Given this list of marker genes TMEM176A, IFI27, INPP5B, INMT, VNN1, CPT2, REEP6, XIST, FMO1, C11orf54, CYP2B6, G0S2, LASP1, EHHADH, ALDOB (aldolase, fructose-bisphosphate B), CAT, ALDH1A1, SLC31A1, RGN, IDI1, CD1D, PDZK1, LYZ, HSD17B10 (NCBI Gene Id 50828), SULT1B1, PHLDA1, SERPINA12, AKR1C4, FABP1, OSTC, KLKB1, NOCT, S100A10, IGFALS, MIX23, OTC, TP53INP2, BPHL, ALDH3A2, ZAP70, RDH16, CA3, here is a description of the gene set: Human Gene Set: VARELA_ZMPSTE24_TARGETS_DN species: Mus musculus Top genes down-regulated in liver tissue from mice with knockout of ZMPSTE24. from publication Varela I, Cadiñanos J, Pendás AM, Gutiérrez-Fernández A, Folgueras AR, Sánchez LM, Zhou Z, Rodríguez FJ, Stewart CL, Vega JA, Tryggvason K, Freije JM, López-Otín C (PMID 16079796) Zmpste24 (also called FACE-1) is a metalloproteinase involved in the maturation of lamin A (Lmna), an essential component of the nuclear envelope. Both Zmpste24- and Lmna-deficient mice exhibit profound nuclear architecture abnormalities and multiple histopathological defects that phenocopy an accelerated ageing process. Similarly, diverse human progeroid syndromes are caused by mutations in ZMPSTE24 or LMNA genes. To elucidate the molecular mechanisms underlying these devastating diseases, we have analysed the transcriptional alterations occurring in tissues from Zmpste24-deficient mice. We demonstrate that Zmpste24 deficiency elicits a stress signalling pathway that is evidenced by a marked upregulation of p53 target genes, and accompanied by a senescence phenotype at the cellular level and accelerated ageing at the organismal level. These phenotypes are largely rescued in Zmpste24-/-Lmna+/- mice and partially reversed in Zmpste24-/-p53-/- mice. These findings provide evidence for the existence of a checkpoint response activated by the nuclear abnormalities caused by prelamin A accumulation, and support the concept that hyperactivation of the tumour suppressor p53 may cause accelerated ageing.